The following is a description of a gene set: Mouse Gene Set: GOCC_DNA_REPLICATION_FACTOR_A_COMPLEX A conserved heterotrimeric complex that binds nonspecifically to single-stranded DNA and is required for multiple processes in eukaryotic DNA metabolism, including DNA replication, DNA repair, and recombination. In all eukaryotic organisms examined the complex is composed of subunits of approximately 70, 30, and 14 kDa. species: Mus musculus, and this is the list of marker genes: Smarcal1, Cdc5lrt10, Bcas2, Cdc5l, Xpa (xeroderma pigmentosum, complementation group A), Cdc5lrt8, Rpa3, Cdc5lrt7, Cdc5lrt5, Ercc5, Rpa2, Plrg1, Cdc5lrt6, Rpa1, Prpf19, Tonsl, Helb, E2f6, Cdc5lrt9, Cdc5lrt1, Cdc5lrt4